Given this list of marker genes APH1A, NCSTN, MMP16, MMP14, PSENEN, TIMP1, APH1B, TIMP2, PSEN2, TGFBR3 (NCBI Gene Id 7049), PSEN1, here is a description of the gene set: species: Homo sapiens part of: Signaling by TGFBR3 This subpathway includes the post-translation modification reactions of TGFBR3 including its plasma membrane localization and extracellular regulation by MT-MMPs and Gamma-secretase (Knappenberger et al.,2017, Velasco-loyden et al.,2004, Blari et al.,2011). Reactome Pathway: TGFBR3 PTM regulation